Given this list of marker genes RIPK3, FADD, CD14, LY96, RIPK1, TICAM1, CASP8, TLR4, TICAM2, here is a description of the gene set: species: Homo sapiens Human Gene Set: REACTOME_TRIF_MEDIATED_PROGRAMMED_CELL_DEATH TRIF-mediated programmed cell death